Given this list of marker genes GIT1, CHMP2A, TPRG1L, ADARB1, TLR4, FUNDC2, SVIL, ZNF672, PIGS, UFD1, CDYL, NUDT16L2P, PLIN2 (NCBI Gene Id 123), ARHGEF1, NKX2-5, ITSN1, ZNF511, IFIT2, RALY, KCNE1, DNAJB8, GALR2, MORN2, BAHD1, HSBP1L1, TUSC2, TARBP2, CIBAR1 (NCBI Gene Id 730572), PHLDA3, NKRF, PAQR4, TTC27, KLHL3, VCL, KLF11, KCNAB2, ADORA2B, TMEM223, SNX1 (sorting nexin 1), ANO7L1, TMEM53, NYX, CDK11A, RUNX1, OSER1, AGGF1, TMEM250, EPAS1, SLC25A48, CEP164, NPR1, IL7R, PNPLA3, IGFBP7, TMEM127, NUCB1, STARD7, IQSEC1, DAG1, CD52, ABHD4, DTX4, SLCO3A1, KCTD6, STYXL2, SLAMF9, PCP2, POLR2I, KAZN, MECR, PIP4K2A, AQP3, INF2, GGA2, ABCG2, LMCD1, ANGPTL4, SERPING1, VLDLR (NCBI Gene Id 7436), SEPTIN9, KCNK13, PRCP, ARRDC4, EGFL7 (NCBI Gene Id 51162), VCF1, TMEM266, LFNG, MGAT4B, FOLR3, PPP1CC, MS4A14, DOCK11, CLCN5, NCOA1, STAC3, RGS3, TECR, PDZD11, URGCP, PARVG, CD82 (CD82 molecule), CHST12, STAT6, AUP1, AKT1, TGFB1, ETS1, ANKRD13A, MCUB, CHST14, SIGLEC1, TP53I11, NUP214, SSBP3-AS1, LPXN, CALHM2, SIGLEC15, SCFD2, SIPA1L2, GLIPR2, TTC39B, B3GLCT, BLVRB, CHI3L2, GPR146, MAP3K1, CHKA, LTBP3, SIVA1, CD47, ME3, TOP1MT, BCAR1, CYLC2, ERGIC3, GNAQ, CRYBG1, ATP11B, CABLES1, RHOU, OAS3, OAS1, TMEM60, AATBC, SFMBT1, AGPAT2, ADAM17, FCGRT, RRS1, S100A9, MRTFA, DDIAS, PPP2R2D, C1orf162 (NCBI Gene Id 128346), DISP1, FKBP5, CMPK2 (cytidine/uridine monophosphate kinase 2), LINC01550, ITGA3, TRMO, MAF1, CEMP1, ANXA5, TMEM200B, TOMM5, KLHL18, OS9, FHL1, TMEM42, STK17B, CARD14 (NCBI Gene Id 79092), FAM228A, TP53I3, GFUS, ALDOA, DGKZ, TRPV2, EIF4EBP2, TMC6 (transmembrane channel like 6), EHD4, REEP5, LOXHD1, HPCAL1, DECR1, TMEM243, FCHO1, VASP, CD151, NLRC4, ST6GALNAC2, LPCAT3, LY6E, RARA, TSC22D1, MGAT3, SEMA3G, here is a description of the gene set: Genes up-regulated in anergic CD4 Th1 cells: wildtype versus EGR2 knockout. studied in species Homo sapiens T cell anergy is one of the mechanisms contributing to peripheral tolerance, particularly in the context of progressively growing tumors and in tolerogenic treatments promoting allograft acceptance. We recently reported that early growth response gene 2 (Egr2) is a critical transcription factor for the induction of anergy in vitro and in vivo, which was identified based on its ability to regulate the expression of inhibitory signaling molecules diacylglycerol kinase (DGK)-a and -z. We reasoned that other transcriptional targets of Egr2 might encode additional factors important for T cell anergy and immune regulation. Thus, we conducted two sets of genome-wide screens: gene expression profiling of wild type versus Egr2-deleted T cells treated under anergizing conditions, and a ChIP-Seq analysis to identify genes that bind Egr2 in anergic cells. Merging of these data sets revealed 49 targets that are directly regulated by Egr2. Among these are inhibitory signaling molecules previously reported to contribute to T cell anergy, but unexpectedly, also cell surface molecules and secreted factors, including lymphocyte-activation gene 3 (Lag3), Class-I-MHC-restricted T cell associated molecule (Crtam), Semaphorin 7A (Sema7A), and chemokine CCL1. These observations suggest that anergic T cells might not simply be functionally inert, and may have additional functional properties oriented towards other cellular components of the immune system. from publication Zheng Y, Zha Y, Spaapen RM, Mathew R, Barr K, Bendelac A, Gajewski TF (PMID 23548837) Human Gene Set: GSE46242_CTRL_VS_EGR2_DELETED_ANERGIC_TH1_CD4_TCELL_UP